The following is a description of a gene set: Mouse Gene Set: GOBP_REGULATION_OF_FIBROBLAST_PROLIFERATION Any process that modulates the frequency, rate or extent of multiplication or reproduction of fibroblast cells. species: Mus musculus, and this is the list of marker genes: Nupr1, Fth1, E2f1 (NCBI Gene Id 13555), Sod2, Uts2r, Cdc73, Fosl2, Hras, Esr1, Ski, Tgfb1, Ccnb1, Ctc1, Trim32, Igf1, Ngfr (nerve growth factor receptor (TNFR superfamily, member 16)), Kmt2c, Dhx9, Ifi30, Zmiz1, Sphk1, Myc, Wnt5a, Brk1, Gstp1, B4galt7, Hmga2, Fbln1, Pawr, Creb1, Egfr, Nbn, Icmt, Aqp1, Kmt2a, Lif, Rnaseh2b, Fndc3b, Phip, Pdgfrb, Med25, Nras, Mmp9, Ddr2, Cdc6, Dach1, Lig4, Morc3, Cd248, Tgif1, Med31, Btc, Fbxo4, Egf, Cdk4, Bax, Pex2, Abl1, Trp53, Cdkn1a, Fntb, Pdgfc, Tsc2, Ifng, Prkdc, Bmi1, Pdgfa, Kcnn4, Dab2ip, Cd74, Xrcc4, Cdk6, Brpf1, Smarca2, Pdgfd, Fbrs, Pdgfra, Agt, Ager, Nf1, Sfrp1, Gas6, Rasgrf1, Grk2, Pla2g1b, Wnt1, Fgf10, Sirt6, Inca1, Bmyc, Cd300a, Pparg, Parp10, Lta, Serpine1, Cav1, Dicer1, Pmaip1, Ptprz1, Ptprv, Ccna2, Mir744, Emd, Wnt2, Rasa1, Anxa2, Agtr2 (NCBI Gene Id 11609), Nlrc3, Myb (myeloblastosis oncogene), Socs1, Trp53inp1, Ndufs4, Uts2, Ereg, Zmpste24, Fn1, Jun, C1ql4, Pdgfb, Pml (promyelocytic leukemia), Mif, Ing5, Men1, Lzts2, Itgb3 (NCBI Gene Id 268495), Il13, Cripto